Given this list of marker genes EPN1, NECAP1, AP2M1, KCNQ5, CLTB, CLTCL1, EPS15, EPS15L1, NCALD, AP1G1, AP1S3, AP1B1, IGF2R, AP2B1, STON1, AP3M1, MYCBPAP, CLBA1, AP2A1, AP2S1, EPN2, AP1M2, VPS33A, EPN3 (NCBI Gene Id 55040), VPS41, CLTC, SCN10A, SLC18A3, AFTPH, PICALM, SCLT1, SYNRG, AP2A2, AP4B1, AP4M1, BAIAP2L2, ENTHD1, AP1G2, AP3M2, AP1S2, AP3B1, CLINT1, TBC1D5, SYNJ1, BTBD8, AP1M1, SGIP1, NECAP2, AP1S1 (NCBI Gene Id 574017), CLTA, STON2, here is a description of the gene set: A membrane coat found on coated pits and some coated vesicles; consists of polymerized clathrin triskelions, each comprising three clathrin heavy chains and three clathrin light chains, linked to the membrane via one of the AP adaptor complexes. studied in species Homo sapiens Human Gene Set: GOCC_CLATHRIN_COAT